The following is a description of a gene set: Human Gene Set: GOBP_REGULATION_OF_GLOMERULAR_FILTRATION Any process that modulates the frequency, rate or extent of glomerular filtration. Glomerular filtration is the process in which blood is filtered by the glomerulus into the renal tubule. studied in species Homo sapiens, and this is the list of marker genes: TTR, F2R, F2RL1, EMP2 (epithelial membrane protein 2), PTPRO, CORO2B, GAS6, GJA5, ADORA1, PDGFB, CYBA